The following is a description of a gene set: Any process that modulates the frequency, rate or extent of calcium ion transmembrane transport. Mouse Gene Set: GOBP_REGULATION_OF_CALCIUM_ION_TRANSMEMBRANE_TRANSPORT species: Mus musculus, and this is the list of marker genes: Clec4b1, Cacng1, P2rx5, Ucp2, Cracr2a, Smim6, Vdac1, Drd2, Diaph1, Dhrs7c, Tlr9, Stim2, F2r, Hrc, Gpr35, Tmem38a, Stac3, Ntsr1, Ehd3, Agtr1a, Hpca, G6pdx, Tspan13, Stac, Ednra, Tgfb1, P2rx1, Ppp3ca, Gsto1, Pkd2, Gimap5, Ptger3, Psen2, Ubqln1, Slc9a1, Plcg1, Ptk2b, Nipsnap2, Tmc2, Plcg2, Cyba, Cxcl9, Ppp3cc, Jsrp1, Cxcr3, Xcl1, Htt, Fyn, Jph2, Ppp3cb, Sestd1, Trdn, Gstm7, Tmc1, Cacng6, Cav3, Aplnr, Adrb2, Hspa2, Myo5a, Akap5, Cacna1d (calcium channel, voltage-dependent, L type, alpha 1D subunit), Cacna2d1, Il13, Tgfb2, Cav1, Cemip, Dmd, Trpc1, Ubash3b, Coro1a, Gimap3, Bax, Stim1, Tmbim6, Atp1b1, Cx3cl1, Bin1, G6pd2 (NCBI Gene Id 14382), Plp1, Stac2, Sri (sorcin), Dysf, Prkd1, Thy1, Bmp4, Gper1, Epo, Calm3, Pdpk1, Cacnb4, Rapgef3, Ppp3r2, Fgf14, P2ry6, Afg3l2, Ubr3 (NCBI Gene Id 99175), Slc8a1, Cxcl10, Selenon, Capn3, Gnb5, Kcnn4, Cacnb2, Cacna1c (NCBI Gene Id 619317), Sumo1, Cxcl11, Fkbp1a, Chd7, Sln, Itgb3, Atp2a1, Casq2, Vmp1, Asph, Pde4d, P2rx7, Calm2, Camk2d, Ptpn22, Ank2 (NCBI Gene Id 99906), Casq1, Mettl21c, Bcl2 (B cell leukemia/lymphoma 2), Jph3, Hap1, Atg5, Ahr, Strit1, 1810037I17Rik, F2, Lyn, Cacnb1, Oga (NCBI Gene Id 76055), Abl1, Prkce, Pik3cg, Trpc3, P2rx4, Cacna1f, Adrb1, Mrln, Ffar1, Atp1a2, Adcyap1r1, Rgs9, Ptpn6, Akt1, Rem1, Cd19, Nol3, Bak1, Fmr1, Grm6, Cbarp, Calm1, Ngf (NCBI Gene Id 18049), Prnp, Lhcgr, Grin1, Dbi, Fbxo11, Ahnak, Nppa, Fcrl5, Ywhae, Cacnb3, Drd4, Drd1, Spg7, Mcub, Fkbp1b (NCBI Gene Id 14226), Ryr2, Pln, Ms4a2, Pml, Snca, Bdkrb1, Akap6, Zfas1, Stimate, Cd4, Ppp3r1 (NCBI Gene Id 19058), Npsr1, Gpr39, Ms4a1, Tmem38b, Lime1, F2rl3, Gjc2